The following is a description of a gene set: studied in species Homo sapiens Human Gene Set: GOBP_NEGATIVE_REGULATION_OF_CELL_CYCLE_G2_M_PHASE_TRANSITION Any signaling pathway that decreases or inhibits the activity of a cell cycle cyclin-dependent protein kinase to modulate the switch from G2 phase to M phase of the cell cycle., and this is the list of marker genes: DONSON, NABP1, INTS3, PABIR1, HUS1, NAE1, TICRR, BRCA1, CDK1, BARD1, AURKB, ABRAXAS1, BLM, ORC1, ATR, CHMP4C (NCBI Gene Id 92421), RFPL1, GTPBP4, WEE1, SYF2, NABP2, STK35, RINT1, VPS4A, CLSPN, RAD17, MBTPS1, ATF5, RAD21, CHFR, CDK5RAP3, AVEN, MACROH2A1, MBTPS2, NBN, RAD50, HUS1B, TOPBP1, MIR195, BRCC3, TAOK2, CDKN1A, INIP, TAOK3, CDC6, ZFYVE19 (zinc finger FYVE-type containing 19), BABAM1, FHL1, TAOK1, PLK1, MRNIP, ZNF830, BABAM2, CDC14B, BRSK1, IER3, ATM, DTL, CHEK1, RBBP8, HEXIM2, MIIP, GPR132, MRE11, UIMC1, PDIK1L, NOP53, MIR19B1, FZR1, FOXO4, ETAA1, FOXN3, PINX1, TRIM39, PKMYT1